Given this list of marker genes Rbx1, Elobl, Vhl (NCBI Gene Id 22346), Neurl2, Eloc, Elob, Cul2, here is a description of the gene set: A protein complex that possesses ubiquitin ligase activity; the complex is usually pentameric; for example, in mammals the subunits are pVHL, elongin B, elongin C, cullin-2 (Cul2), and Rbx1. Mouse Gene Set: GOCC_VCB_COMPLEX studied in species Mus musculus